The following is a description of a gene set: Mouse Gene Set: GOMF_SIGNALING_RECEPTOR_BINDING species: Mus musculus Binding to one or more specific sites on a receptor molecule, a macromolecule that undergoes combination with a hormone, neurotransmitter, drug or intracellular messenger to initiate a change in cell function., and this is the list of marker genes: Prl3d2, Cer1, Htr5b, Tnfsf14, Myoc, Pla2g5, Ptpn2, Ptger1, Ntrk2, Tarm1, Hsp90b1, Tspoap1, Idua, C1ql1, Psca, Itgb4, Sec14l1, Fga, Ankrd13c, Cntfr, Il18, Fcgr3, Icam5, Smad3, Dbi, Ano1, Amelx, Pkd2, Defb7, Fgf14, Pdia3, Tenm2, Dock4, Nrg4, Ambn, Pla2g1b, Sema5b, Yes1, Pdgfd, Cmtm5, Calm2, Nck2, Psmc5, Cort, Esp38, Skint4, Pmch, Wfikkn1 (WAP, FS, Ig, KU, and NTR-containing protein 1), Lamb2, Il20, Scp2, Il17f, Epha7 (NCBI Gene Id 13841), Asxl1, Skint6, Ccl12, Ang2, Mdm2, Skint8, Snx6 (sorting nexin 6), Neo1, Il36b, Fgfr1, Pdcl3, Ptprz1, Drd1, Bmp15, Syndig1, Alkal2, Sema4b, Tnfsf13, Reln, Adra2c, Sipa1l1, Pdgfrb, Cnpy4, Ppp1r9b, Crp, Traf3ip1, Ihh, Map1a, Btnl4, Ccl11, Nlgn3, Cnrip1 (NCBI Gene Id 77064), Dll1, Tgfbr1, Fbln5, Ccnb1-ps, Grb14, Ryk, Isg15, Cxcl1, Clec2g, Fgf1, Tub, Col2a1, Il19, Prl3c1, Ostn, Il21, Exoc4, Sytl5, H2-M10.2, Sema3f, Fem1al, Ptprf, Plaur, Tac2, Myh9, Trdn, Cxcl15, Bmp8b, Prl4a1, Snx5 (NCBI Gene Id 99195), Gstm7, Esm1, Fgf23, Ubxn2a, Arhgef16, Cnih1, Amn, Tg, Gipc1, Mesd (mesoderm development LRP chaperone), Vegfb, Btnl12, Cklf (chemokine-like factor), P2ry2, Sectm1a, Gna14, Neto1, Shc2, Bcap31, H2-Q6, Ccl19-ps1, Plg, Mchr1, Ednrb, Vegfc, Stap1, Ankra2, Gm13272 (NCBI Gene Id 545648), Ccl2, Psen1, Ripk1, Ripk2 (NCBI Gene Id 70170), Tbp, Hap1, Hsd17b7, Pdyn, Ensa (NCBI Gene Id 99644), Cadm4 (NCBI Gene Id 260299), Ang6, Defb9, Cxcl13 (NCBI Gene Id 70783), Defb14, Angpt4, Fbn1, Sema4f, Pik3ip1, Ror2, C1qtnf12, Gla, Cacng2, Lhb, Atp1a3, Ly6c1, Ptprc, Rit2, Atp2a2, Arfgef2, 6030468B19Rik, Spon2, Kiss1, Lama3, Usp20 (NCBI Gene Id 98993), F11r, Gfra1, Rapsn, Sned1, Wnt16, Ncoa2, H2-T5, Gabarapl1, Lta, 2410137M14Rik, Prl3d1, Ddt, Fgf6 (fibroblast growth factor 6), Il1a, Prl3b1, Lypd1, Slc39a1, H2-M10.4 (histocompatibility 2, M region locus 10.4), Ltb, Cga, Zfp369, Slit2, Arnt2, Lifr, Npw, Prl7a2, Nars1, Fgf3, Nppb, Pik3cg, Icosl, Reg3a, Tob1, Fgf18, Prmt2, Spred3, Pick1, Rnf41, Gdf11, Gpha2, Casr (NCBI Gene Id 12374), Marco, Lynx1, Mmp14, Bambi, Clec2f, Nr0b2, Palm, Fpr-rs4, Mpp1, Ace, H2-M10.5, S100a7l2, Btnl6, Crebbp, H2-Ea, Il17ra, Zfp106, Cd70, Gria2, H2-T23, Il10, Adam17, Rnf126, Ufd1, F7, Dscam, Arhgef12, Inhbc, Dvl1, Ptprd, Fst, Itga9, Tspan8, Angpt1, Ptpn11, Ifna9, Grk2, Rabep2, Gnal, Washc1, Ccl25, Pitpnm3, Agr2, Il36g, Ptk6, Cacng3, Efnb1, Wnt1, Ifnk, Sytl3, Smad7, Asxl2, Cav2, Ikbkb, Eng, Nrg2 (NCBI Gene Id 381149), Cmtm8, Kcnj10, Il11, Stub1, Ndp, Tln2, Nedd4, Csf2, Tlr6, Il17c, Fasl, Nms, Il34, Taf6, Lgals3, Slurp2, Cd300lf, Rara, Cxcl2, Cpne3, Lrp4, Esp22 (exocrine gland secreted peptide 22), Grip2, Lpin1, Fpr-rs3, Ucn, Bmp4, Nefm, Tap1, Sag, Adm, a, Dlg4, Igf1, Gnaq (NCBI Gene Id 71788), Epha4, Wnt9a (wingless-type MMTV integration site family, member 9A), Iapp, Retnlg, Synj2bp, Crlf2, Svep1, Cblc, Ccl24, Ifnz, Zpr1, Pira13, Lrp1, Npb, Il1r1, Arpc2, Adra2a, Jaml, Sh3gl1, Skint2, Hmga1, Tlr4, Prl2b1, Pou2f1, Rtp1, Gpnmb, Pik3r2 (phosphoinositide-3-kinase regulatory subunit 2), Rspo3 (NCBI Gene Id 72780), Slc6a4, Ifna16 (NCBI Gene Id 230398), Btc, Dnaja1, Uts2b, Pibf1, Arr3, Adrb3, Insl3, Prl7b1, Ar, Il1rapl1, Tiam1, Tacc1, Emp2, Eif3a, Vps35, Syk, Pdcd6ip, Ctnnb1, Zfp110, Ywhag, Hjv, Hck, Dut, Rapgef2, Sh2d3c, Gdf9, Grin2b, Traf6, Gsk3a, Hilpda, Drd3, Trak1, Fgg, Defb10, Tigit, Tnfsf13b, Tgfbr2, Efna1, Tap2, Zbtb16, Tnc, Gdf6, Itga3, Cxcl14, Camk2a, Sema4g, Bmp5 (NCBI Gene Id 12160), Sh2b1, S1pr3, Ifna11 (NCBI Gene Id 230403), Spp1, Raet1d, Shc4, Cyrib, Stat1 (signal transducer and activator of transcription 1), Reep1, Cfc1, Nenf (neuron derived neurotrophic factor), Il12b, Irak4, Sema3a, Myo5b, Gm13283 (NCBI Gene Id 545645), 3110082I17Rik, Nherf2 (NHERF family PDZ scaffold protein 2), Cbl, Irak1, Copa, Gusb, Cask, Pspn, Clstn3, Tgfb1i1, Esp8 (NCBI Gene Id 100126778), Dpp4 (dipeptidylpeptidase 4), Grb2, Snx25, Nherf1, H2-T22, Gja1, Tulp3, Slurp1 (NCBI Gene Id 80539), Ccn3, Madcam1, Hdgf, Erfe, Lrig2, Gnao1, Lama4, Rer1, Gopc, Gabrb1 (NCBI Gene Id 320243), Gdf5, Adh7, Cd81, Fzd7, Ncstn, Traf4, Gnrh1, Erbb4, Nherf4, Enpp1 (ectonucleotide pyrophosphatase/phosphodiesterase 1), Hcrt, Rnf43, Pth2, Cd80, Tmeff1, Thbs1, Fcgr1, Unc93b1, Il17b, Ccl21a, Lcp1, Il33, Trim37, App, Plcl1, Grem1, Hmgb1, Clec2d, Cx3cl1, Cxcl17, Prok2, Apoa2 (NCBI Gene Id 11807), Babam2, Mbl2, Traf1 (TNF receptor-associated factor 1), Defb6, Tradd, Six3, Nxph3, Fgf20, Grn, Kng1, Commd1, Fgf16, Gprc5c, Tcam1, Sntg2, Ifna13, H2-M10.6, Hnf4a, Ifna6, Rpgrip1l, Reg3g, Ifnl2, Sfrp2, Traf2, Grin2a, Utrn, Ric3, Sema3c, Ifna1, Ccl3, Cd2ap, Itgbl1, Hsp90aa1, Defb2, Efnb3, Gdf1, Vav3, Sorbs1, Skint10, Tff1 (NCBI Gene Id 21784), Esr2, Hgf, Fam3b, Gfral, Il13, Itgb5, Itch, Cxcl12, Ttr, Il1rn (interleukin 1 receptor antagonist), Plscr4, H2-M10.1, Kcna5, Fpr2, Flot2, Cd40lg, Btnl9, Kctd10, Nppc, P2rx7, Col3a1, Rala, Casp3, Leprot, Atp5f1b, Scg2, Nes (NCBI Gene Id 97066), Calm1, Scgb3a1, Ly6e, Ngef, Gna13, Ncor1, Gab2, Erap1, Nrg1, Lama1, Angpt2, Spx, Ccl28, Pdgfra, Grk3, Fgf15, Gna15, S100a13, Ighe, Irs1, Ifna4, Gpr15lg, H2-Q4, Itga2b, Clic6, Icam2, Pitpnm2, Gm44501, Bmp7, Reg1, Esp23 (exocrine gland secreted peptide 23), Myo1c, Phb1, Cabp1, H2-Q10, Erbb3, Cd9, Penk, Il1b, Prl6a1 (prolactin family 6, subfamily a, member 1), Drd2, Gprasp2, Izumo1r, Nradd, Nrtn, Wipi1, Trim25, Fpr-rs7 (NCBI Gene Id 321021), Ghrl, Igfbp5, Saa2, Snx17, Ntf3, Ppp2ca, Nmb, Gabra5, Pira12, Jchain, Cdk5, Plscr1, Amh, Efna2, Cd226 (NCBI Gene Id 225825), Creg1, Fcrl6, Casp8 (NCBI Gene Id 12370), Igha, Cd151, Itgb7, Crtam, Aimp1, Elapor2, Tff2, Il25, Lpl, Retnlb, Gphn, Zdhhc17, H2-M10.3, Anks1b, Ikbkg, Lancl1, Lgi1, Mst1, Dner, Frk, Rab4a, Znrf3, Shc3, Pira2, Tgfbrap1, Abl1, Ccn5, Cxcl10, Smurf1, Cnpy3, P2rx4, Itgb3, H2-Q1, Ern1, Ccdc88a, Insl5, Nxph4, Lingo1, Ppy, Itga10, Cxcl5, Nlgn2 (NCBI Gene Id 216856), Itga7, Vwf, Reep2, Nr1h2, Angptl8, Irs3, Defb40, Spred2, Ddx54, Cdnf, Sema6d, Nlgn4l, Esp15, Ins1, Dll4, Shc1, Hspa1a (heat shock protein 1A), Epo, Prl2c2, Egfr, Pitpnm1 (NCBI Gene Id 98172), Arf4, Cmtm3, Ccl27a, Wnt8a, Fkbp1b, Nrros, Ly96, Ncor2, H2-Q2, Grip1, Btn2a2, Shisa6, Itgb1 (integrin beta 1 (fibronectin receptor beta)), Mill2, H2-M2, Ighg1, Metrn, Tlr1, Nrxn2, Nppa, Sema3g, Tnfsf12, Pglyrp1, Taok2, Eda, Adora1, Nptn, Prl3d3, Dnajc14, Esp36, Ccl27b, Nisch, Nsf, Maf1, Mdk, Mag, Gabrg1, Hfe, Cnot9, Defb5, Dlk2, Prl8a9, Homer2, Hdgfl3, Prkn, Nampt, Apoa5, Inha, Nrip1, Icam4, Fgf7, Il6st, Aqp1, Rchy1 (ring finger and CHY zinc finger domain containing 1), Ang, Pdgfc (platelet-derived growth factor, C polypeptide), Cacng8, Ly6g2, Prl5a1, Htt, Strap, Rln3, Clec4d, Fermt3, Pdpn, Trpc1, Stoml2, Jak3, Osm, Crhr2, Map7, Edn1, Hba-a2, Ly6c2, Fnta, Nmu, Anxa5, Sema3e, Pex14, Hsp90ab1, Rtp2, Tmbim1, Fgf17, Htr1a, Adipoq, Lrrc32, Vtn, Il9, Hspa8, Tln1, Wnt7b, Cltc (NCBI Gene Id 97762), Bex1, Sema3b, Rasa1, Trh, Pias3, Pla2g2c, Tgfbr3, Adam9, Tnfsf11, Cd320, Nxnl1, Cd2, Uts2, Gm6040, Abca12, Ptch2, Dhh, Defb47, Dok2, H60c, Il22, Cck, Snw1, Plcl2, Ccl4, Lyn (LYN proto-oncogene, Src family tyrosine kinase), Il23r, Npff, Bank1, Rpl11, Fgf11, Dll3, Pdpk1, Skint9, Ophn1, Itgal, Apoc3, Egfl7, Calr, Itga11, Fshb, Esp18, Ccn2, Tafa1, Pyy, Il4, Tsnax, Plat, Grem2, Ldlrap1, Grb10 (NCBI Gene Id 67977), Ccl27al, Capn3, H2-M9, Jag2, Dst, Bmp6, Dab2ip, Sema6a, Rnd1, Dvl2, Bicd1, Cxcl11, Adam28, Nup85, Agap2, Mpp4, Dnm3, Tespa1, Bag6, Gripap1, Alkbh1, Tgfb2, Prl2c3, Plscr2, Itgb1bp1, Flrt3, Ccl19-ps4, Itga4, Gh, Adam25, Sema5a, Fbn2, Igsf1, Btn1a1 (NCBI Gene Id 12231), Ccl1, Arrdc3, Wnt10a, Sema7a, Nxph1, Gm13276, Wnt8b, Fndc5, Btnl10, Wnt2, Skint5, Pigr (NCBI Gene Id 18703), Tnfsf15, Lamb1, Ccl19-ps6, Efnb2, Fpr1, Ilk, Cd160, Nbl1, Ephb2, Efna5, Cdk5r1, Ccl21d, Oxtr, Aak1, Wnt3, Dvl3, Mill1, Tspan4, Sstr3, Tnfsf4, Prkar2a, Shank3, Il27, Phaf1, Vcp, Prl8a1, Spred1 (NCBI Gene Id 99293), Med1, Igfals, Ifna14, Angptl3 (NCBI Gene Id 30924), Klb, Cdh17, Ifng, Lrrtm2, Sla, Cntf, Atp2b2, Jakmip1, Hspe1-rs1, Cthrc1, Defb37, Fam3c, Rln1, Dnm2, Itgb2, Ticam2 (NCBI Gene Id 225471), Ngfr, Fgf4 (fibroblast growth factor 4), Dnajb11, Clec2e, Il17d, Ptpn1, Ccl22, Ptpn6, Esp34, Gdf15, Ccl5, Il17rc, Gas6, Serpine2, Nlgn1, Fus, Reg3b, S1pr2, Ucn2, Slit3, Wnt6, Il36rn, Ghrh, Tirap, Tspan9, Rgma, Vegfa, Stx1b, Pebp1, H2-Eb2, Cartpt, Acvr1c, Mstn, Nsmaf, Socs5, H2-T3, Actn1, H2-T13, Wnt10b, Cnih4, Fgf5, C3, Gria1, Nsg1 (neuron specific gene family member 1), Crh, Cd22, Nfatc4, Pirb, Bmp2 (NCBI Gene Id 98992), Gna11, Gnat1, Tslp, Itgb8, Amacr, Ccr2, Grm5, Lilrb4a, Mmrn2, Flna, Dock2, Derl1, Nectin4, mt-Nd2, Gsk3b, Cacng4, Fem1b, Ccl20, Prl2a1, Lefty2, Tshb, Cadm1, Pth, Wnt5a, Hamp2, Pdgfb, Thy1, Ifna7 (interferon alpha 7), Cdh5, Spg21, Erbin, Itga1, Jag1, Vtcn1, Il12rb1, Socs3, Gfap, Enho, Dkk2, Ighg2b, Dazap2, Vgf, Efemp1, Asxl3, Picalm, Dlg2, Hmga1b, Lep, Ly6a, Ptk2b, Osgin1, Ly6i, Skint1, Rasl11b, Osmr (oncostatin M receptor), Ntrk1, Ecrg4, Itgax, Lrg1, Rspo4, Cd44, Defb46, Ccl19, Ighm, Mif, Ly6g6e, Adcyap1, Tafa3 (TAFA chemokine like family member 3), Pgr, Ly6h, Qrfp, Irs4, Sema6b, Kcnj8, Wnt4, Il3, Ppia, Mecr, Lmbrd1 (NCBI Gene Id 98639), Esr1, Areg (amphiregulin), Uchl1 (ubiquitin carboxy-terminal hydrolase L1), Bex2, Gnaz, Itgae, Kng2, Rabep1, Sos1, Fgf10, Dab2, Cnih3, Gdf7, Prl3a1, Itgav, Nol3, Il16, Itga6, Stat3, Cflar, Ifna12, Serpine1, Muc4, Dnaja3, Mog, Rnf135, Ly6g, Ccl21b, Btnl2, Ccl19-ps3, Pcna, Ccdc88c, Srpx2, Fgf8, Cxcl3, Tafa4, Clec2h, Agtr1b, Pdzk1, Tnfsf8, Rtn4r, Mup1, Mmp13, Itgb2l, Sh2b3, Ppbp, Manf, Mfsd6, Fgf2, Canx, H60b, Btnl1, Col16a1, Gmfg, Fadd, Lilra6, Traf5, Lif, Cd86, Lhfpl4, Pilra, Smo, Ccn1 (NCBI Gene Id 99596), Ren1, Fcnb, Ccl17, Il23a, Mrap2, Gmfb, Avpr1a, Vip, Il15, Pnoc, Cd274, Ptprj, Emilin1, Taf4, H2-Q7, Tcim, Lgals1, Dmd, C1qtnf4, Blk, Stc1, Siva1, Ptpn14, Clcf1, Trem2, Trak2, Cd74, Grap, Alkal1, Cdh26 (NCBI Gene Id 381409), Tns2, Usp15, Hspa1b, Apbb3, Usp33, H2-D1 (NCBI Gene Id 547343), Lgals9, Cd8b1, Cdc42, Ulbp1, Hcst (NCBI Gene Id 23900), Gnai3, Gpr17, Npffr2, Ifna2, Ncl, Dtx1 (deltex 1, E3 ubiquitin ligase), Rimbp3, Trp53, Calca, Adora2a, Inhbb, Timp2, Jak2, Grp, Snx1, Shh, Akap5, Creb3, Gdnf, Defb39, Kir3dl2, Adam24, Pgf, Edn2, Avp, Dlg1, Igf1r, Col4a3, Ptpa, Cckbr, Timp1, Elmo2, Clptm1 (cleft lip and palate associated transmembrane protein 1), Cr2, Gkn1, Sytl4, Apob, Il17a, Bok (BCL2-related ovarian killer), Slc6a3, Xcl1, Add1, Plpp3, Fkbp1a, Gm13277, Thpo, Defb3 (NCBI Gene Id 27358), Vcam1, Ighg3, Adam8, Tnr, Slit1, Wnt9b, Rspo1, Wnt11, Pxn, Bdnf, Tyrobp, Skint11, Syt1, Clec2i, Arrb2 (NCBI Gene Id 216869), Megf10, Notch4, Nr3c1, Ncoa6, Izumo1, Flt3l, Cav1, Ntn3, Fabp4, Gnas, Nodal, H2-M5, Fgf13, Pfn1, Gdf2, Ap2a1, Erbb2, Gdf3, Dmtn, Nectin2, Gnai2, Defb48, Prl8a8, Mup20, Esp6, Rtp4, Adam26a, Mavs, Pik3ap1, Agrn, Apoa1, Crlf1, Cfl1, Itga8, Edaradd, Ecm1, Npy, Aplp1, Itprid2, Ms4a1, Ccl9, Prok1, Caprin2, Fam83b, Adam15, Nrg3, Nicol1, Oprk1, Gnai1, Sh2b2, Ereg, Artn, H2-T10, Lrrc4b, Mtss1, Lck, Ly6m (NCBI Gene Id 67038), Dkkl1, Scube3, Dlg3, Marchf8 (NCBI Gene Id 71779), Igfl3, P4hb, Prl7d1, Hbegf, Bbs1, Cmtm2a, Itgad, Arnt, Traf3ip2, Tlr5, Plcg1 (NCBI Gene Id 99130), Hamp, Skint3, Efna3, Fgf9, Notch1, Esp4, Ly6f, Ceacam1, Fgf12, Atxn2, Ncoa3, Csf3, Ang5, Pde4d, Fer, Ermap, Il5, Sema4c, Prkce, Ang4, Ctsg, Neto2 (neuropilin (NRP) and tolloid (TLL)-like 2), Igf2, Itprid1, Il31, Sacs, Bmp10, Agrp, Ighg2c, Dnm1, Esp31, Vegfd, Cd177, Arhgef1, Msmp, Lag3, Atrnl1, Kir3dl1, Tnn, Tnfsf18, Ppp1r1b, Prl7c1, Fem1a, Galnt11, Tubb5, Pcsk9, Snx27, H2-K1, Gabarap (NCBI Gene Id 56486), Adrb2, Angptl2, Tgfbr3l (transforming growth factor, beta receptor III-like), Lefty1, Apln, Jam3, Kif5c, Tac4, Kdr, Trf, Lrp6, Frs2, Klra17 (NCBI Gene Id 170733), Adcy6, Gm13271, Ltbp1, Ifnb1, Tnk2, Cx3cr1, Prl8a6, Thbs4, Dkk3, Smarcd3, Pf4, Snx4, Il36a, Icam1, Gdf10, Nf2, Esp1, F2r, Ccnb1, S1pr1, Lrpap1, Timm50, Ctnnd1, Slc2a2, Panx1, Srms, Pycard, Ctf1, Adm2, Ccl8, Ccl19-ps5, H2-T24, Ccn4, Gpi1, Ptch1, Inhbe, Prnp, Tgfb1 (NCBI Gene Id 21803), Mfge8, Angptl1 (angiopoietin-like 1), Ibsp, S100a7a, Insl6, Bdkrb2, Ahr, Smarcd1, Jam2, C1qtnf9, Cxcl16, Sema4a, Map3k7, C1qtnf2, Zp3, Itgb6, Lrp12, Tafa5, Atp5f1a, Sh3bp1, Fpr3, Defb34, Npvf, Sst, C1qbp (NCBI Gene Id 28127), Cul3, Fgb, Sectm1b, Chuk, Arrb1, Gast, Prl, Fgf22, Hrg, Mia, Pecr, Esp3, Apela (NCBI Gene Id 100038489), Selp, Defb8, Wnt2b, Nucb2, Snx2, Csf1 (colony stimulating factor 1 (macrophage)), Bmal1, Fes, Prl2c1, Klk1b3, Cnih2, Prlh, Nrxn1, Sema4d, Raet1e, Pdia4, Tlr9, Ifna5, Chn1, Fgf21, Trip6, Esp24, Il6ra, Shank2, Homer1, Ccl21f, Ifne, Sdcbp, Ccl7, Anxa7, Fzd1, Frs3, Pthlh, S100a14, Saa3, Mr1, Prdm4, H2-T15, Cib2, Egf, Itgb1bp2, Metrnl, Epgn, Pdgfa, Angptl6, Flrt1, Ccrl2, Gfer, Csnk2b, Clu, Ntf5, Gna12 (NCBI Gene Id 14673), Glmn, Prdx5, Nck1 (non-catalytic region of tyrosine kinase adaptor protein 1), Egfl8, Shank1, Vav2, Fbrs, Defb15, Rarres2, Acp4, Comp, Defb33, Sqstm1, Cish, Lgr4, Tafa2, Tgfa, Agt, Oprd1, Pik3r1, Fcna, Il2, Msn, Myo9b, Epb41l1, Chac1, Bex3, Pilrb1, Hif1an (hypoxia-inducible factor 1, alpha subunit inhibitor), Ap2m1 (NCBI Gene Id 11773), Edn3, Klrd1, Socs1, Wnt3a, Smurf2, Bmp3 (bone morphogenetic protein 3), Saa1, Ly6g6g, Efna4, Wif1, Insr, Fiz1, Mrap, Cmtm2b, Ifnl3, Pacrg, Skint7, Wnt7a, Scyl2, Ifna15, Hyal2, Tyk2, Lbp, Gm13275, Itgam, Crkl (v-crk avian sarcoma virus CT10 oncogene homolog-like), Pilrb2, Tnfsf9 (tumor necrosis factor (ligand) superfamily, member 9), Src, Dkk4, Ube2i, Bmp1, Gata3, Cd276, Gal, H2-M1, Il7, Fermt1, Sct, S100a4, Bglap2, Mtrnr2l7, Oxt, Agtr1a, Arhgef11, Prl7a1, Tgfb3, Sytl1, Irs2, Ebi3, Gip, Nts, Dkk1, Fgr (NCBI Gene Id 14191), Ccl21e, Nxph2, Itpripl1, Park7, Eps8l1, Cd4, Rtp3, Ucn3 (NCBI Gene Id 83428), Ccn6, Rspo2, Clec11a, Tollip, Klk1b4, Rtn4rl1, Rack1 (NCBI Gene Id 14694), Calm3, Myd88, Ccl6, Fap, Anks1, Lama2, Smad6, Marchf1, Il22b, Inhba, Sytl2, Chrm3, Fermt2, Fpr-rs6, Lama5, Sema3d, Sema6c, Dusp3, H2-M11, Fyn, Ngf, Kl, Psap, Retnla, Ctf2, Fn1, Itga2, Ogn, L1cam, Pten, Tnf, Ccl26, Jak1, Aip, Klrk1, Arap1, Ifnab, Il1f10, Prl8a2, Osgin2 (oxidative stress induced growth inhibitor family member 2), Wls (wntless WNT ligand secretion mediator), Cd1d1 (NCBI Gene Id 99710), Prl2c5, Bglap, Socs2, Adrb1, Tlr2, Fbln1, Gphb5, Il24, Retn, Grin1, Usp4, Ptpn4, Homer3, Cripto, Tubb3, Stc2 (NCBI Gene Id 20857), Cxcl9, Axin1, Adam18 (a disintegrin and metallopeptidase domain 18), Eml2, Cpe, Pomc, Ptn, Bmp8a (bone morphogenetic protein 8a), Hba-a1, Fzd8, Igsf11, Hmgb2, Itga5, Arpp19, S100b, Crk, Gcg, Lrp2 (NCBI Gene Id 99378), Cd244a, Rasgrf1 (NCBI Gene Id 26449), Ins2, Flot1, Sfrp1, Apoe, Flrt2, F2, Wnt5b, Lgals8, Galp, Prtn3, Dand5, Cdc42ep2, Defb11, Prkca, Cblb, Ppargc1a, Tac1, Defb4 (defensin beta 4), Defb38, Tnfsf10, F2rl2, Cmtm7, Wfikkn2, Shisa7, Cxadr, Traf3, Colec10, Ulbp3, Cd36, Gnat2, Ptk2, Il12a, Smad2, Magi3, Ubqln1, Gba1, Rab8b (RAB8B, member RAS oncogene family), Esp16, Kitl, H2-Eb1, Igfbp2, Npnt, Frmd5, Tmed2, Abca1, Il1rap, P2ry1, A2m, Il6, Ep300, Magi2, H2-M3, Calcb, Myl12a, Defb1, Gnat3, Necab2